The following is a description of a gene set: Human Gene Set: HP_ABNORMAL_CIRCULATING_GASTRIN_CONCENTRATION An abnormal concentration of gastrin in the blood. species: Homo sapiens Abnormal circulating gastrin concentration, and this is the list of marker genes: CDKN1B, MEN1, MCOLN1, CDKN2B, CDKN1A, CDKN2C